The following is a description of a gene set: Genes containing one or more binding sites for (ZNF514) in their promoter regions (TSS -1000,+100 bp) as identified by GTRD version 20.06 ChIP-seq harmonization. species: Homo sapiens from publication Yevshin I, Sharipov R, Kolmykov S, Kondrakhin Y, Kolpakov F (PMID 30445619) Human Gene Set: ZNF514_TARGET_GENES, and this is the list of marker genes: STAT6, LINC00431, CPN2, NOL6 (nucleolar protein 6), GSN, MED21, RND1, CWC25